Given this list of marker genes MAX, MSRB1, UBXN4, CXCL5 (NCBI Gene Id 6374), NDST2, ID1, CCDC68, MTG1, C1S, ISG20, TAP1, PSME2, UBE2L6, SQOR, DYRK2, RARS1, OPTN, SLC25A28, VPS26C, HLA-F, BTN2A2, ERAP1, TXNL4B, IFRD2, CALCOCO2, SLC15A3 (NCBI Gene Id 51296), RFX5, PARP3, TRMO, RNF114, IFI30, TGM2, ASPM, CASP7, PSMA6, ACSL5, IRF1, ACSL3, VEGFA, IDO1, HLA-E, JAK2, LILRB1, DESI1, PMAIP1, PHEX, LTBR, NBN, PSME1, TAP2, CTBS, FLT3LG, TRIM31, SOD2, CD40, CASP1, CXCL11, HEG1, CTDSP2, LXN, ERLIN1, CXCL2, BTN3A1, SEMA3F, CEP15, BCO1 (NCBI Gene Id 60483), MLF1, ARID5B, NR2C2, BTN3A2, DOCK4, CD47, DENND5A (NCBI Gene Id 23258), PSMB10, PUS3, BMAL2 (basic helix-loop-helix ARNT like 2), KLF4, ARIH1, DNAJC1, FAM111A, RBMS1, VPS13C, RBCK1, RNF115, CIR1, STS, CD74, PSMA3, PLAAT4, MTIF2, PLEKHF2 (NCBI Gene Id 79666), IL1R2, BACH1, LAP3, ZNF277, WARS1, NDUFA9, SLC25A22, ITM2B, LARP1, MET, IL15RA, KIF2A, PSMB8, CTSC, SOS1, ASCC3, HLA-G, RAB27A, GSAP, IFI35, GGCX, APOL6, DUSP10, KIAA0586, NAMPT, ATF3, USO1, KDM7A, SBNO2, DPYD (dihydropyrimidine dehydrogenase), ZFP36, PCSK6, ZNF22, CD38, ITGAL, SIX1, PTGIS, MAFF, CYLD, STAT3, AHCYL2, SLC14A2, BATF3, ATP10D, PSMA4, PPWD1, MTHFD2, TRIM22, NFE2L3, IRF8, BTN3A3, ICAM1, CLEC2B, NMI (N-myc and STAT interactor), TRIM38, C5orf15, ITGB6, DNAJC7, RYR2 (ryanodine receptor 2), SECTM1, PSMB9, TRAFD1 (TRAF-type zinc finger domain containing 1), TLR3, CEACAM1 (NCBI Gene Id 634), TMEM140, LSM12, AK2, CASP8, RBM7, TAPBPL, MCL1, CTSS, PCM1, SP140L, MREG, ZNF7, APOL3, LGALS13, GUK1, AK4, ADAP1, APOL1, GBP2, APOL2, TBC1D5 (NCBI Gene Id 9779), RIOK3 (NCBI Gene Id 8780), SOCS1, EIF3M, DNPEP (NCBI Gene Id 23549), RTP4, CDC42EP4, LEPROTL1, WDR25, DRAM1, RNF19B, SMC6, TNFRSF1B, GBP1, C3, GSTK1, FADS3, TOP1, CREG1, NKX3-1, ST8SIA4, CFH, IGFLR1, KARS1, ACO1, here is a description of the gene set: We investigated at which stage of maturation commitment to a stable Foxp3-expressing phenotype takes place. We assessed stability of Foxp3 expression in thymic Foxp3+ Treg subsets of different maturity, defined by CD24 expression. Next we compared gene expression profiles of Foxp3+ Treg subsets (+) of different maturity (24lo, 24int, 24hi) and could identify a set of genes that were specifically up or downregulated in Foxp3+ Tregs, but not in Foxp3- conventional T cells, in a maturation-dependent manner. species: Homo sapiens from publication Toker A, Engelbert D, Garg G, Polansky JK, Floess S, Miyao T, Baron U, Düber S, Geffers R, Giehr P, Schallenberg S, Kretschmer K, Olek S, Walter J, Weiss S, Hori S, Hamann A, Huehn J (PMID 23420886) Genes up-regulated in T conv: peripheral lymph nodes versus thymic CD24 high. Human Gene Set: GSE42021_TCONV_PLN_VS_CD24HI_TCONV_THYMUS_UP